The following is a description of a gene set: from publication Chen Y, Wang X (PMID 31504780) studied in species Homo sapiens Genes predicted to be targets of miRBase v22 microRNA hsa-miR-592 in miRDB v6.0 with MirTarget v4 prediction scores > 80 (high confidence targets). Human Gene Set: MIR592, and this is the list of marker genes: BST1, ERBB3, BCCIP, PRELID2, C5orf24, ROCK1, TCF12, ATP1A4 (NCBI Gene Id 480), CDK8, PUDP, ZSCAN5A, CERS6, SART1, TPM3, LAMC1, GPR65, NFIA, STPG2, DHX15, ANKRD36B, CLPX, MTHFD2L, LRRC4C (NCBI Gene Id 57689), C2orf88, BCL11B, GDF11, TFAP2A, F8, RNF10, PROX1, FAM240A, SCRT1, CCDC149, RFX1, TRIP12, CHGB, ANKRD36C, AKAP7, INO80E, ID2, PLXNA2, CDIN1, TSHZ1, RRN3, PDE4D, PRUNE2, HEXIM1, NR2E1, CEACAM21, MXRA7, DCLK1, CFAP44, KCNA2, PAFAH1B1, PDE3A (phosphodiesterase 3A), IGF1, FBXW2, TRDN, DENND11 (NCBI Gene Id 57189), GIGYF2 (GRB10 interacting GYF protein 2), GCSAML, ARHGEF9, RHPN2, NRDE2 (NCBI Gene Id 79790), TMED2, ZSWIM6, ATMIN, BCL11A (NCBI Gene Id 55085), KLHL29, PTHLH, SCD, XG, GLCE, ZNF484, TSC22D1, LRRFIP2, SLC39A10